Given this list of marker genes MYO5B, NDUFA5, SNX18, HUNK, SMAD2, HSPA4, ELOVL7, TMEM207, ACVR2B, CAPZA2, RALGDS, FRMPD4, NHLRC2, SELE, C5orf24, ZCCHC4, ASCL1, SLCO1B3, NUDT11, ABHD5, ZNF81, SUCNR1, GNB2, ZFP37, NME5, UST, AGPAT5, UBE2K, TENT2, NRK (NCBI Gene Id 203447), KRCC1, HOXA10, CWC27, EEA1, DCDC2, NEUROG2, TMEM38B, GABRA1, MLX, CSGALNACT2, TMEM245, SPIN1, KAT6A, PDE4D, BCL11B (NCBI Gene Id 64919), ARHGEF40, CYB5A, ZBTB34, STRIP2, CDK6, RORA, RAB3GAP2, ARHGAP5, BRWD3, CXADR, ANLN, MSH4, CCNE2, TMEM123, DIPK2A, SP5, ETS2, PKD1L2, LIN54, ETNK1, PARP8, BEND4, CADM2, ZNF615, SNX4, CCL2, NLN, IL22, ATXN1, VEGFC, NGLY1, MICB, STMN2, KIRREL1, HGF, DCUN1D1, RANBP6, LIN9, AHI1, MRPL42, TCERG1, ACAN, TTC8, SLC24A2, PSMB2, RNF180, FBXL5, WDR35, HIBADH, SMKR1 (small lysine rich protein 1), GNPNAT1, PDE4B, NCK1, STK38L, OR7A5, ZBTB46, MSI2, DKK2, CFAP418, EDAR, CCL8, MREG, SP4, AHDC1, FGF5, ANKRD34B, KIF20A, MAP2K4, CA12, TM9SF2, SPOPL, SCML1, MAP9, NKX2-2, RNF14, FAM222B, TET3, RNF214, DUSP8, MCTP2, GPANK1, HECTD1, SOS1, IKZF2, PDCD1 (NCBI Gene Id 56179), PRRG1, HAPLN1 (NCBI Gene Id 1404), CLVS2, HNMT, PELI1, ZNF655, CEBPB, PITX2, SRP68, ZNF587B, SLC2A12 (NCBI Gene Id 155191), HSBP1, RELCH, TMEM108, PEX2 (peroxisomal biogenesis factor 2), DSEL, DOK6, PPM1B, RBM27, CEP350, TLE4, PRDM1, ZNF423, RPRD2, DUSP6, ACKR4, PRPF18, HMGN5, TNRC6A, NUP35, ZNF711, DBR1, FLG2, KANSL1L, ITGB8, NEDD4L, ZNF16, ACSL6, CDC40, ZNF280D, RAB22A, PAPPA, CDK20 (NCBI Gene Id 23552), PDE10A, CEMIP, ABCA8, KLHL28, TCAIM, ZDHHC5, SNX17 (NCBI Gene Id 9784), CSMD3, MEOX2, PRDM5, CDC73, MYO5C, GADD45A, RPL34, DSG2, CRIM1, HES1, NUP98, DUSP19, CNTN4, EN1, RFK, EYS, VSTM2A, SUMO4, RGS7BP, C4orf33, TLCD4, CENPJ, ARL15, RIC1, PRH2, SEL1L, TMEM267, CCDC34, PSMC3IP, TBC1D19, FOXM1, TMED5, CCND1, ASGR2, MBLAC2, TBC1D9, FAT4, NRN1, LSAMP, LEPR, PREX2, ADAM10, SP1, PRDM11, PARD6B, BRWD1, SLC35F5, TGFA, DCAF10, ABHD18, GOSR1, CPEB4, NRDE2, CAAP1, FPR3, NCOA1, EPB41L2, HECTD4, MACC1, ACSL4, TXLNB, NR4A3, AGL, PLD5, CAMSAP2, FABP2, FOXD2, ATF7, EXOC7, NSUN3, ELAVL4, SYT14, MYT1L, TFDP1, AFF1, PCDH11Y, MAP2, EIF2S2, GABRG1, WNT5B, FAM161A, FNIP1, ITGA2, LPAR1, RASGRF1, PTPN14, NRG2, EN2, MECP2, IQSEC2, MAPK6, STYX, CCDC126, ZNF527, PNPT1, VGLL3, SEC63, ASTN2, LDLRAD4, WNT5A, ABAT, RGS4, LCA5, TNFAIP3, NTF3, ABTB3, DLG2, TAF4B, BSDC1 (BSD domain containing 1), PMPCB, PLPP3, PCDHB15, AHR, MYO5A, PDE7B, MED13, RAC1, CCDC191, MICU3, MED23, SHPRH, SEMA3D, OCRL, AAK1, EGFL6, MMP14, RREB1, SMAD6, STEAP2, CGNL1, CDS1, CAV2, SCRN3, GATA3, RABEP1, STBD1, MORN4 (MORN repeat containing 4), CDC14A, XIRP2, SMARCAD1, TMEM185A, C3orf70, NIPBL, C8orf33, AHSA2P, HR, RPRD1A, UBE3A, APOBEC4, MCFD2, RAP1B, LRP12, MAP4K3, ATAD2B, CELF4, PGGT1B, PLN, SNTG1, MZT1, FDXACB1, YME1L1, PPP2R3A, RGS21, TMEM192 (NCBI Gene Id 201931), CYP24A1, GOLGA8M, LRRTM3, ADD3, KLHL29, SRSF7, ABR, SEPSECS, RTKN2, CYYR1, TAFA2, GLO1, PIGW, ANOS1, WASHC4, LPL (lipoprotein lipase), RGS14, BMP2, TACC1, HOMER1, PCGF5, SLIT3, GABRG2, MAP2K6, MOSPD2, PHACTR2, TSPOAP1, ZNF131, MBNL3, ZIC3, CCDC47, ASB5, SP3, MKX, TCF24, DMXL1, SLITRK1, ADCYAP1, PALS2, NIBAN1, NOVA1, ZSWIM6, LTBP1, C10orf90, RSF1, C11orf58, PRR16, GAS7, FAF2, GRAMD1B, CACNB4, DPY19L4, TRPS1, YTHDF1, PNLIPRP3, SGPP1, TAF5L, ATAD2, MOCS3, TMPRSS11B, PCDH11X, FAM47E-STBD1, KCTD20, PAQR3, IGFBP3, ITIH5, MIPOL1, ZCCHC9, ZFP36, MEF2D, BOLA3, POLK, NEO1, TM4SF19 (NCBI Gene Id 116211), SRSF5, FZD3, DCUN1D5, TBC1D23, SLC22A10, PPIL3, N4BP2 (NCBI Gene Id 55728), C11orf87, NETO1, CDC42BPB, MIS18A, GCLM, CNTN1, ACTR3, LNPK, PTGER3, WDR72, here is a description of the gene set: Human Gene Set: MIR374A_5P Genes predicted to be targets of miRBase v22 microRNA hsa-miR-374a-5p in miRDB v6.0 with MirTarget v4 prediction scores > 80 (high confidence targets). species: Homo sapiens from publication Chen Y, Wang X (PMID 31504780)